The following is a description of a gene set: studied in species Homo sapiens from publication Chen Y, Wang X (PMID 31504780) Human Gene Set: MIR3529_5P Genes predicted to be targets of miRBase v22 microRNA hsa-miR-3529-5p in miRDB v6.0 with MirTarget v4 prediction scores > 80 (high confidence targets)., and this is the list of marker genes: RAD18, SEMA3A, UBE2E3, ELMOD2, PITPNM3, ZBTB26, SGPP1, OGN, NHLRC2 (NCBI Gene Id 54835), SDE2, GALNT15, SMAP1, PPP4R1, GDF6, NRARP, EIF4G2, ESRP1, MCTP2, NR6A1 (NCBI Gene Id 2649), TXLNG, RAB30, CXCL11, FZD4, LZTS3, CREBBP, TLCD2, LINGO2, ZCCHC2, DNAJC30, MTMR2, MDM2, PEX11B, NHLRC3, MTO1